Given this list of marker genes GRHL2, VSX1, COL8A2, ZEB1, OVOL2, RPGRIP1, here is a description of the gene set: Human Gene Set: HP_VERY_LOW_VISUAL_ACUITY studied in species Homo sapiens A reduction in visual acuity with best corrected visual acuity between 1.40 (20/500) and 1.89 logMAR (up to roughly 20/1590). Very low visual acuity